Given this list of marker genes SNRK (SNF related kinase), CNOT2, FOS, ARHGEF18, CRY2, AQP3 (NCBI Gene Id 360), HSD17B11, NDRG2, LINC00623, ENTPD4, TXNIP, DYRK1A, FYB1, IRS2, SKAP1, CYTH4, MOAP1, BTG1 (NCBI Gene Id 694), YTHDF3, CIRBP, TSPYL4, PNN, PYCARD, HAPLN2, LEF1, NDRG3, SAMHD1, TSC22D3, PIK3IP1, CLK1, ARHGDIB, RPS27, EPHA4, PDE4D, RRN3P1, IL11RA, MCUB, FAM53B, NR4A2, TNFAIP3, ARHGAP15, NDUFA1, CERNA1, DNAJB1, ALOX5AP, TSPAN14, SUN2, ZNF331, IFITM1, JUNB, HMGB2, MYBL1, RASGRP2, PLCG1, ARL4A, PLCL2, PIK3R1, KLF3, TPM2, TRIM62 (tripartite motif containing 62), PIK3CA, CRTC3, CDR2, CITED2, MYL12A, PTP4A1, CD48, CD52, ITGB2 (NCBI Gene Id 3689), S100A4, MGP, HERC5, ZNF226, LMF1, PCNP, RNF44, PPP3CA, BIN1, HECA, PLAC8, FAM8A1, SH3BGRL, PCMTD2, DSTYK, FBXO21, IFITM2, DPYD, PTPRA, JADE1, RIPOR2, MSRA, PPP1CB (NCBI Gene Id 5500), RALGAPA1, SLC35D2, ENSG00000274253, ARL4C, KLF2, NUP160, CEP43, CLEC2B, SETD2, CD69, HAUS5, RLF, CCDC59, SLC2A3, TNIK, KLHL3, SORL1, PIKFYVE, PRKACB, MBNL2, PER1, CNN2, TOP2A, TOX, NEFL, TSPYL1, LYPD3, TRMO, MROH7, PBXIP1, ICAM3, LIMD2, SIK1, USP34, CHD1, CCNL1, ANXA1, MX2, FHL1, SLC46A3, ARHGEF6, DSC1, UQCRB, MXI1, PIAS2, SIGIRR, ANAPC15, EVI2B, HAUS3 (HAUS augmin like complex subunit 3), USP3, CFH, KAT6B, PRKCQ, FCGBP, NR3C2, TTC17, ZNF639, TOB1, COX7C, MED6, CMC4, TENT5C, LYRM9, MYO1F, ITM2B, ZFP36L2, DYRK2, KANSL2, JUN, ADD3, NPAS3, RAB11FIP2, EVI2A, RAP1GAP2, PTPN4, CSGALNACT1, DOCK2, C1R, OSBPL8, PHC1, SYNJ2, TMC6, PITPNC1, RB1CC1, MGAT4A, MARCHF8, SGSH, RPL31, SERINC5, HIC2, HBP1, KLHL11, NUCB2, FRAT1, LEPROTL1, MAP3K5, AGBL2, UVRAG, GZMK, SEMA4C, BNIP3L, TMX4, YPEL5 (NCBI Gene Id 51646), KLRB1, MAPRE2, ATG2A, here is a description of the gene set: With increasing age, the ability of the immune system to protect against recurring infections or to control chronic infections erodes. The objective of the current study was to identify gene expression signatures in elderly CD4 T cell responses Human Gene Set: GSE36476_CTRL_VS_TSST_ACT_16H_MEMORY_CD4_TCELL_YOUNG_UP Genes up-regulated in comparison of untreated CD4 memory T cells from young donors versus those treated with TSST at 16 h. from publication Yu M, Li G, Lee WW, Yuan M, Cui D, Weyand CM, Goronzy JJ (PMID 22434910) species: Homo sapiens